The following is a description of a gene set: Human Gene Set: HP_NONPROGRESSIVE_ENCEPHALOPATHY Nonprogressive encephalopathy species: Homo sapiens, and this is the list of marker genes: UNC80, MED23, PNPT1, HSD17B10, FBLN1